The following is a description of a gene set: Hand tremor studied in species Homo sapiens An unintentional, oscillating to-and-fro muscle movement affecting the hand. Human Gene Set: HP_HAND_TREMOR, and this is the list of marker genes: AARS2, ZFYVE26, MFN2, KCNN2, TAF1, GJB1, SAMD12, PMP2, STUB1, DRD3, YEATS2, NGF, ABCB6, TRAPPC6B, CNTN2, SMN2, PDK3, CAMTA1, POLG, MARS1, FGF14, NOP56, SMN1, MARCHF6, SPTLC1, VRK1, GBA2, GCK, ADRA2B, PDGFB, NEFL, TFG, TSHR (thyroid stimulating hormone receptor), TOR1A, ERLIN2, TBC1D24, PHIP, CTNND2, ATP7B, SLC6A17, PLA2G6, ANO3, RAB3GAP2, ZFR